The following is a description of a gene set: species: Mus musculus electronically inferred by orthology from the curated human pathway This event has been computationally inferred from an event that has been demonstrated in another species.<p>The inference is based on the homology mapping from PANTHER. Briefly, reactions for which all involved PhysicalEntities (in input, output and catalyst) have a mapped orthologue/paralogue (for complexes at least 75% of components must have a mapping) are inferred to the other species. Reactome Pathway: Zinc efflux and compartmentalization by the SLC30 family part of: Zinc transporters, and this is the list of marker genes: Slc30a8, Slc30a5